Given this list of marker genes ERCC3, XPA, ERCC5, XPC, DDB2, ERCC4, ERCC2, PTCH1, here is a description of the gene set: studied in species Homo sapiens Flat nasal alae An abnormal degree of flatness of the Ala of nose, which can be defined as a reduced nasal elevation index (lateral depth of the nose from the tip of the nose to the insertion of the nasal ala in the cheek x 100 divided by the side-to-side breadth of the nasal alae). Human Gene Set: HP_FLAT_NASAL_ALAE